Given this list of marker genes VMP1, LPIN1, NABP1, ABLIM1, EI24, CDKN1A, BTG2, ISOC1, MDM2 (NCBI Gene Id 84825), MALAT1, TP53INP1, ADGRE1, SERPINA3, CCNG1, YPEL3, TXNIP, CD53, TOB1, DHRS3, PMM1, TMEM185A, ASNSD1, here is a description of the gene set: Genes up-regulated in FL5.12 cells (pro-B lymphocyte) in response to cisplatin. Human Gene Set: BRACHAT_RESPONSE_TO_CISPLATIN studied in species Mus musculus from publication Brachat A, Pierrat B, Xynos A, Brecht K, Simonen M, Brüngger A, Heim J (PMID 12447701) DNA microarrays are powerful tools for the analysis of gene expression on a genomic scale. The importance of individual regulatory events for the process under study can however not be deduced unequivocally without additional experiments. We devised a strategy to identify central regulators of cancer drug responses by combining the results of microarray experiments with efficient methods for phenotypic testing of candidate genes. We exposed murine FL5.12 pro-B cells to cisplatin, camptothecin, methotrexate or paclitaxel, respectively and analysed the patterns of gene expression with cDNA microarrays. Drug-specific regulatory events as well as intersections between different apoptotic pathways, including previously studied responses to staurosporine and interleukin-3 (IL-3) deprivation, were identified. Genes shared by at least three pathways were chosen for further analysis. Ectopic expression of three such genes, TEAP, GP49B, and Lipin1 was found to have an anti-proliferative effect on pro-B cells. Interestingly, we identified hemoglobin alpha as a strong pro-apoptotic regulator. While hemoglobin-expressing cells were growing normally in the presence of IL-3, they displayed accelerated apoptosis with similar kinetics as Bax overexpressing cells upon IL-3 removal. The pro-apoptotic effect of hemoglobin was suppressed by Bcl-2 and was characterized by enhanced stimulation of caspase activity.